The following is a description of a gene set: studied in species Mus musculus Reactome Pathway: Nucleotide biosynthesis electronically inferred by orthology from the curated human pathway This event has been computationally inferred from an event that has been demonstrated in another species.<p>The inference is based on the homology mapping from PANTHER. Briefly, reactions for which all involved PhysicalEntities (in input, output and catalyst) have a mapped orthologue/paralogue (for complexes at least 75% of components must have a mapping) are inferred to the other species. part of: Metabolism of nucleotides, and this is the list of marker genes: Impdh2, Gart, Paics, Cad, Adsl, Pfas, Adss1, Gmps